The following is a description of a gene set: Human Gene Set: HE_LIM_SUN_FETAL_LUNG_C7_COL20A1_POS_SCHWANN_CELL from publication He P, Lim K, Sun D, Pett JP, Jeng Q, Polanski K, Dong Z, Bolt L, Richardson L, Mamanova L, Dabrowska M, Wilbrey-Clark A, Madissoon E, Tuong ZK, Dann E, Suo C, Goh I, Yoshida M, Nikolić MZ, Janes SM, He X, Barker RA, Teichmann SA, Marioni JC, Meyer KB, Rawlins EL (PMID 36493756) species: Homo sapiens COL20A1+ Schwann, and this is the list of marker genes: GPR17, PSMB8, PDLIM1, PLSCR3, SHROOM4, GRIP2, FST, UTP15, DOCK8, DYNLT2B, IL11RA, IFI16, COL28A1, IGFBP7, LMO3, SP100, RPS4Y1 (ribosomal protein S4 Y-linked 1), MYO1C, GRID2, ACTC1, ADAMTSL1, CYP4V2, TMEM176A, SRPX, ALDH1A3, LYPD6, COL20A1, CYTL1, ENG, KLF4, DGKB, SFXN3, HSPB2, CASP4 (caspase 4), P3H2, CD44, HMCN1, MAL2, NTM, IL1RAP, DPY19L3, TMEM176B, BGN, EGLN2 (egl-9 family hypoxia inducible factor 2), GABRA2, PLAC9, COL6A3, ELN, AFAP1L1, ITGA2, NMI, TGFBI, TFAP2C, ARHGAP31, S100A4, USP53, ANGPT1, MGAT4C, ITM2A, FBN1, ALDH1A1, CHST9, PDGFA, SMIM5, PLA2G4A, IL17RC, TMEM35B, ITGA1, NFIX, ANXA1, FRAS1, CTNNA3